The following is a description of a gene set: Mouse Gene Set: MIR_6346 Genes predicted to be targets of miRBase v22 microRNA mmu_miR_6346 in miRDB v6.0 with MirTarget v4 prediction scores > 80 (high confidence targets). from publication Chen Y, Wang X (PMID 31504780) species: Mus musculus, and this is the list of marker genes: Nptn, Scn7a, Hoxa9, Utp15 (UTP15 small subunit processome component), Map6d1, Ctxn3, Adgra1, Fezf1, Krt90, Mon2, Nog, Inpp5a, Fign, Rock1, Prkg1, Fga, Smyd1, Ptpn9, Xpnpep2, Dach2, Epas1, Kcnk13, Ppfia2, Mapk10, Gas7, Epb41l2, Lamtor1, Acvr1b (activin A receptor, type 1B), Pramel7, Sec24c, Fgf13, Neurod4, Elavl4, Zfp78, Plagl2, Acap2, Sinhcaf, Stx8, Mpdz, Mapt, Sowahc (NCBI Gene Id 70860), Slc5a3, Adipor1, Lrrc4b, Kcnip2, Ift56, Plekha1, Mcm6, Brdt (NCBI Gene Id 338496), Fkbp14, Sptlc2, Braf, Rlim, Gpr158, Cdhr1, Slc38a10, Kat7, Thrb, Cyp2ab1, Calm2, Abhd12, Rab11b, Dars1, Gulp1, Rab4b